Given this list of marker genes MT-CO1, LMNA, OBSCN, DPM3, CRPPA, LAMA2, FDX2, MT-CO3, ANO5, LPIN1, POPDC3, PYGM, SNUPN, here is a description of the gene set: Human Gene Set: HP_HIGHLY_ELEVATED_CREATINE_KINASE An increased CPK level between 4X and 50X above the upper normal level. Highly elevated creatine kinase studied in species Homo sapiens